The following is a description of a gene set: Any process that results in a change in state or activity of a cell or an organism (in terms of movement, secretion, enzyme production, gene expression, etc.) as a result of a type I interferon stimulus. Type I interferons include the interferon-alpha, beta, delta, episilon, zeta, kappa, tau, and omega gene families. Mouse Gene Set: GOBP_RESPONSE_TO_TYPE_I_INTERFERON species: Mus musculus, and this is the list of marker genes: Mul1, Ythdf2, Ifnz, Trim41, Gm13283, Stat1, Ifna14, Ifna12, Gm13277, Ifnar2, Trim6, Mettl3, Ifih1, Oas1h, Lsm14a (LSM14A mRNA processing body assembly factor), Zbp1, Irf3, Ifnk, Ifna7, Mx2, Oas1c, Irak1, Ifna4, Ifitm7, Usp18 (ubiquitin specific peptidase 18), Setd2, Ifna13, Ifitm6, Ifna15, Sin3a, Ifna1, Oasl2, Hdac4, Trim56, Gm13275, Samhd1, Oas1b, Smpd1, Oas1g, Ch25h, Oas1a, Gm13271, Cactin, Ifitm2, Cnot7, Cdc37, Ube2k, Ptpn2, Ttll12, Shfl, Ifnar1, Ifne, Ifna11, Eif4e2, Wnt5a, Ifitm3 (interferon induced transmembrane protein 3), Sting1, Oas1f, Oas2, Usp27x, Stat2, Ikbke, Fadd, Ythdf3 (YTH N6-methyladenosine RNA binding protein 3), Gpr108, Gigyf2, Nlrc5, Gm13276 (NCBI Gene Id 545649), Dcst1, Gm13272, Oas3, Oasl1, Ifna5, Mavs, Trim65, Usp29, Isg15, Ifna6, Oas1d, Rnf185, Rbm47, Myd88, Smim30, Ifnab, Jak1, Ifitm1, Ifna16, Trex1, Ifna2, Adar, Mmp12, Irf7, Ifna9, Tyk2, Tbk1, Sp100, Ifnb1, Shmt2, Oas1e